Given this list of marker genes GNB1, CROT, B3GALT4, TLR1, STAB1, SLC13A2, H2BC10, RASSF2, AMHR2, ERC1, INPP5B, MUC6, PSMD9, CHMP2A, SELENOP, CYP51A1, ABCA2, RHBDD3, DLEC1, SNX29, NISCH, MED8, ENTPD1, NEU1, CEACAM7, RGL1, FZD2, GAS7, KCNAB2, IST1, PYGM, CRHR1, CYP27A1, NCF4, AASS, FSCN1, HELZ, DOK1, ETV5, IRF7, PSEN2, SPHK2, NDUFAF1, INTS1, F2R, ATP9B, SMARCD3, UBA7, RAE1, TNFSF14, LTA4H, PIGO, TTC39A, DNAJC11, RAB40B, BANF1, OVOL3, FCHSD2, RELN, NDRG2, AOAH, AKR1A1, MED14 (mediator complex subunit 14), LDLRAD4, COX7A2L, NUP133, SKAP2, GDF15, IRF1, PIP, PRKCD (protein kinase C delta), LGALS3BP, UGT8, LILRA2, CFD, CLTB (clathrin light chain B), CNR1, TMEM268, VAMP2, NAGA, CCN2, RRN3P1, TPD52L2, FCGBP, AIF1, DOCK2, ADA, TNF, VAMP5 (NCBI Gene Id 200553), PHF20, NBR1, CCL5, CLTA, EHD1, ARF3, CDC14B, PTAFR, INPP4B, HLA-DPB1, CYB5R1, PTPA, TAP1, PRCP, CHI3L2, MYCL, TRAF3, GPT, RASSF8, BST1, SH3BP1, ENTPD6, NDUFS3, FLOT2, OAZ2, CYBA, HLA-DRB4, LY86, S100P, GALK2, ZNF185, ARAF, GAS6, CCDC22, HEXA, CYFIP1, DAP, NDUFS7, NFKBIE, KRT85, ATG4A, FCN1, F13A1, IQSEC2, TMEM184B, BABAM2, CD9, CFB, TNFAIP2, ALDH3B1, S100B, DTX2, HDAC5, ZNF652, CD4, HOXB2, MYO1F, BLVRA, PTK2B, CCT6B, TNFRSF14, PSMD4, PPM1H, CD33, BAHD1, KCNB2, ARR3, RHOA, MLX, PARP3, VASH1, PBX2, PDIA4, SIPA1 (signal-induced proliferation-associated 1), VSIG4, PLEKHM2, REM1, PTPRCAP, PLA2G2A, SND1, KCNJ9, ZNF45, HLA-DRB6, IFFO1, TSPAN31 (tetraspanin 31), CNOT3, SCN1B (NCBI Gene Id 6324), PSMB5, PCYT2, HLA-DMB, WDR7, SREBF2 (NCBI Gene Id 6721), TSPAN4, IFITM1, CLK3, NTNG1, PARP2, PTGIR, FKBP2, LRRC37A2, CD72, EIF2B4, PLEKHB2, HTR1E, TNFAIP6, SCN9A, STXBP2, ZNF415, SLC1A4, IL18, here is a description of the gene set: from publication Chaussabel D, Semnani RT, McDowell MA, Sacks D, Sher A, Nutman TB (PMID 12663451) species: Homo sapiens Human Gene Set: GSE360_T_GONDII_VS_B_MALAYI_HIGH_DOSE_MAC_DN Genes down-regulated in comparison of macrophages exposed to T. gondii versus macrophages exposed to 50 worms/well B. malayi. Monocyte-derived dendritic cells (DC) and macrophages (MΦ) generated in vitro from the same individual blood donors were exposed to five different pathogens, and gene expression profiles were assessed by microarray analysis. Responses to Mycobacterium tuberculosis and to phylogenetically distinct protozoan (Leishmania major, L. donovani, Toxoplasma gondii) and helminth (Brugia malayi) parasites were examined, each of which produces chronic infections in humans yet vary considerably in the nature of the immune responses they trigger.